Given this list of marker genes DKK1, TSHZ1, TAPBP, UCHL1, SLC22A18, SLC38A2, CD9, VAMP3, EFEMP1, CITED2, USP53, MKX, DENND2B, STC2, EIF3CL, A2M, ADIRF, MTREX, COL15A1, ARPC1B, SLC6A8, RNF150, EREG, ARID5A, EXT1, TMTC1, FRMD4A, IGFBP7, SLC38A11, ASS1, PTGS1, PIANP, APCDD1, POLE4, ANXA11, FZD7, RPS4Y1, CTSZ, PDE5A, FDFT1, PAPSS2, KRT18, BMP4, FOXF2, NAB1, TRIM28, LUM, GSTT1, HMGA1, KDELR3 (NCBI Gene Id 11015), IGF2R, ELOVL5, PGM5, DANCR, RILPL2, ATP2B1, ARMC9, TSPAN5, BBS7, TRIOBP, ADAMTS1, CALD1, FKBP11, RGS10, SNX9, NES, EHD3, PAX8-AS1, here is a description of the gene set: Reconstitution of telomerase activity by ectopic expression of telomerase reverse transcriptase (hTERT) results in an immortal phenotype in various types of normal human cells, including fibroblasts. Despite lack of transformation characteristics, it is unclear whether hTERT-immortalized cells are physiologically and biochemically the same as their normal counterparts. Here, we compared the gene expression profiles of normal and hTERT-immortalized fibroblasts by using a cDNA microarray containing 20,736 cDNA clones and identified 172 dysregulated genes or expressed sequence tags (ESTs). One of the highly expressed genes in the hTERT-immortalized fibroblasts (hTERT-BJ cells) encodes epiregulin, a potent growth factor. Blockade of epiregulin reduced the growth of hTERT-BJ cells and colony formation of hTERT-transformed fibroblasts. Moreover, inhibition of epiregulin function in immortal hTERT-BJ cells triggered a senescence program. Our results suggest that both activation of telomerase and subsequent induction of epiregulin are required for sustained cell proliferation. Given the significant difference in gene expression profiles between normal and hTERT-immortalized fibroblasts and the close relationship between epiregulin and tumorigenesis, we conclude that hTERT-immortalized cells may not replace their normal counterparts for studies of normal cell biology and that the use of hTERT for expansion of normal human cells for therapeutic purposes must be approached with caution. Genes up-regulated in BJ cells (foreskin fibroblasts) immortalized by expression of TERT. studied in species Homo sapiens Human Gene Set: LINDVALL_IMMORTALIZED_BY_TERT_UP from publication Lindvall C, Hou M, Komurasaki T, Zheng C, Henriksson M, Sedivy JM, Björkholm M, Teh BT, Nordenskjöld M, Xu D (PMID 12702554)